The following is a description of a gene set: species: Homo sapiens part of: Diseases of the neuronal system The process of vision involves two stages; the retinoid cycle which supplies and regenerates the visual chromophore required for vision and phototransduction which propagates the light signal. Defects in the genes involved in the retinoid cycle cause degenerative retinal diseases. These defective genes are described here (for reviews see Travis et al. 2007, Palczewski 2010, Fletcher et al. 2011, den Hollander et al. 2008). Reactome Pathway: Diseases associated with visual transduction, and this is the list of marker genes: RBP1, RBP4, ABCA4, OPN1LW, RDH5, TTR, RLBP1, RDH12, OPN1SW, OPN1MW, STRA6, NAPEPLD, LRAT